Given this list of marker genes GJB6, TRBV7-4, TRBV7-7, GLRA3, ABCC8, CAV2, HTR3C, FCER1G, CDH5, GNG8, PTK2B, KCNF1, CLTC, TRAV36DV7, HFE, ACVR2A, GRM1, GJA1, KCNIP4, DLG3, CHRFAM7A, TRDC, KCNG3, WNT3A, SGCE, SCN2A, NOXA1, CHRNE, ITGA11, TLR2, CATSPERD, CDH22, TRAV27, CD79B, ITGA8, KCNA6, KCNA2, IGF1R, TRBV24-1, GJA9, CHUK, CACNA1C, RAMP3, TRBV6-7 (T cell receptor beta variable 6-7 (non-functional)), TRAV20 (NCBI Gene Id 28663), GNG10, ABCG5, ABCC9 (NCBI Gene Id 102724274, ATP binding cassette subfamily C member 9), GNG5B, TRGV1, SHISA7, GNG3, TRBV14, CHRNA4, OLFM3, SUMO1, CHRNA6, TFRC, CNTFR, GJD3, CD79A, KCNK6, GRIN3B (glutamate ionotropic receptor NMDA type subunit 3B), CATSPERB, CHRNA9, TRBV5-4, ABCD4, NOX3 (NCBI Gene Id 57770), HMGB1, ABHD12, TRBV10-3, HLA-DRA, TRAV34, ATP1A4 (ATPase Na+/K+ transporting subunit alpha 4), TRGV9, KCNS3, PSEN1, IGHM, PSEN2, DPP6 (NCBI Gene Id 653748), KCNJ5, CFLAR, CACNA1E, TRBV12-3, GP1BB (NCBI Gene Id 89199), CTNNA1, TRAV9-1, KCNV1, KCNJ3, CLTB, GNAT3, SNTG2 (NCBI Gene Id 728185), ITGA1, CD74, CACNB3, CAV3, KCNH4, KCNH5, PGM5, TRAV14DV4, CACHD1, COL13A1, GRIK4, KCNN1, CHRNA1, ITGB2, VWC2L, SDCBP, DPP10, TRAV3, GNG2, CHRNA7, KCNA4, GJC2, HLA-F, GNB3, TRAF5, TRBV30, GNG12, TRAV12-1, GJB4, SNAP25, TRBJ2-4 (T cell receptor beta joining 2-4), TRAV8-2, TMEM262 (transmembrane protein 262), LRP1, TBC1D5, HCN1, PDE4B, DLG4, GRIK2, TRBV7-1, HTR3B, C6, IL23R, DRD1, CALM2 (calmodulin 2), GRIA4, ABCA2, HLA-E, TRBV17, IL18R1, CDH10, KCNE1, ITGAD, TRBJ2-3, TRAV8-6 (T cell receptor alpha variable 8-6), LIN7B, ADAM8, TRAV8-4, SLC18A3, SCN4B, TRAJ3, CTNNA2, TRBV6-8, CDH24, FAF1, TRBV10-2, KCNJ4, GP9, GNAQ (G protein subunit alpha q), SCN1B, ITGB1, EFCAB9, KCNG4 (NCBI Gene Id 93107), ATP12A, SGCA, CATSPERE, CDH15, NOX1, KCNE4, SNTA1 (syntrophin alpha 1), CDH7, CHRNA2, CD3G, GJB2 (gap junction protein beta 2), HSPA2, GJB1, GNAI1, HLA-DPA1, TLR1, JAK2, KCNN4, GRIA3, ITGA2B, GJB5, CACNA1D, KCNQ5 (potassium voltage-gated channel subfamily Q member 5), SCN8A, FXYD1, KCNJ8, TRBV6-4, TRBV20-1, CACNG7 (NCBI Gene Id 59284), KCNB1, BMPR1A, ATP1A2, STXBP5, DUOX2, SHC1, TRBV19, CDH17, ITGAE, C8G, ATP1B1, HLA-DQA2, KCNAB3, FADD, CDH18, SCN2B, SCN1A, KCNJ11, NCF4, GJA10, KCNC1, AP2A2 (NCBI Gene Id 25955), TRAV13-1, CD40, SCN5A, GNGT1, CATSPER1, GNB5, HTR3D, CNIH3, CD6 (NCBI Gene Id 923), ITGA7, ATP1B3, VCAM1, CD3D, CDH26, GNG7, ERBB2, ITGAX, HLA-DOA, PRKCA, FXYD4, C2CD6, CDHR3, RAC1, SGCZ, C9, CHRNB3, DAG1, TRGV3, TRAV4, GRID1, KCNQ2, GNB2, GNAI2, HLA-DMB, KCNE3, AP2M1 (adaptor related protein complex 2 subunit mu 1), TRBV29-1, CLTA, ITGB5, KCNC3, INSR, TRBV5-1, TRBV7-2, GRIA2, BIRC2, TRBV18, CALM3, SHISA9, FKBP1A (FKBP prolyl isomerase 1A), KCNA5, SACM1L, GNAS, KCNA7, TRAV8-3, KCNIP3, GRID2, ACVR1, TRAV7, IKBKB, HLA-C, TRAV17, KCNMA1, FCGR3A, TRBJ2-5, GJD2, TMED10, TRBJ1-3, FLNA (NCBI Gene Id 8272), TRAC, TRBC1, TRBJ1-4, IL6ST, LIME1, TRAV41, GP1BA (glycoprotein Ib platelet subunit alpha), CORO1C, FAS, VAMP2, TRAV5, HCN2, LIN7C, KCNQ1, PSENEN, PICALM, LRP6, RET, TRBV4-2, FLOT1, GNB1, AP2B1, TRAV29DV5, ERBB3 (erb-b2 receptor tyrosine kinase 3), GRIA1, KCNV2, ATP6V0D2, GABBR1, TRAF2, TRAV12-3 (T cell receptor alpha variable 12-3), CNTNAP2, CYBB, GJA5 (gap junction protein alpha 5), SCN3B, ATP4A, SHISA6, ITGA3, HLA-DRB3, KCNB2, TF, ACVR1C, GRIN2C (NCBI Gene Id 2905), ABCB6, GNG11, CHRNG, KCNH1, ITGB8 (NCBI Gene Id 3696), TRAV26-2, APC, KCNJ9, APH1B, ACVR1B, NCF1, KCNMB4, TRBJ1-1, TRAV26-1, ITGB6, GJC3, GNAT2, IGHE, CHRNB4, TRAT1, EVC, KCNH2, SNTB2, ITGB7, DLG1, AP2S1, KCNAB2, CACNA1S, IL13RA1, TRBV25-1, AHNAK, ITGA2, KCNS2, GJA4 (gap junction protein alpha 4), GNA14, HTR3E, SYK, TRBJ1-2, CACNG3, LRRC26 (leucine rich repeat containing 26), CDH12, CACNG2, CASP10, GLRB, HLA-A, TRBV11-2 (NCBI Gene Id 28581), SGCB, JUP, TRDD1, KCNG2, TRBV13, C8B, GNA12, TRAV6, GRIN2B, KCNA1, SHISA8, TRAF3, SLC7A5, TRGV4, TRAV30, TGFBR1, SCN11A, HLA-DQB1, CDH8, CASP3, TRBV5-5, AP2A1, LILRA4, CAV1 (NCBI Gene Id 857), TRAV10 (T cell receptor alpha variable 10), NCF1C, ATP1A1, GRIN1, TRBC2, TRBJ2-1, HLA-DOB, CHRNA5, NHERF1, IL6, TRAV12-2, CTNND1, CACNA1H, ITGB4, CHRNB1, HCN3, TRBJ1-6, TMEM249 (NCBI Gene Id 648673), RYR1, BTBD8, NOX4, APH1A, DUOX1, CATSPER3, TRAV35, SNTB1, GNAT1, CHRND, TRGV10, TRAV25, IL6R, TRBV4-1, TRBV16, ABHD6, HTR3A, CACNG5, TRDJ1, KCNJ2, CD8B, CDH11, SGCD, KCNS1, TRBV5-3, KCNQ4, HTRA2, CATSPERG, IL12RB1, TRAV21, PTPN6, HLA-DMA, TRBV27, CACNB2, EMILIN1, CNIH2, GRIK5, CSF2RA, GNGT2, KCNC4, LRRC38, CACNA1G, KCNMB1, CALCR, S100A10, TRBV28, FZD8, LRRC52 (NCBI Gene Id 440699), TRDV1, CHRNA3, LRRC55, CASP8, HCN4, CACNG6, BMPR1B, PDGFRA, EPS15L1, ALCAM, KCNJ14, ABCG8, CHRNB2, KCND3, CDH19, KCND1, CACNB1, STON2, TRADD, LIN7A, CDH20, GABBR2, TRAV22, TRAV1-2, TGFBR3, NOXO1, TRBD1, EVC2, KCNJ6, CD4, GRIN3A, TRBV6-5, MR1, VTN, KCNG1, CACNA2D2, CACNA2D4, TSPAN32, CACNA1B, NEO1, CACNG1, C7, EFCAB7, GJD4, KCNJ16, ATP1B2, TRAV2, LYN, TRBV12-5, KCNE5, TRAV19, FLOT2, TRBV10-1, NOX5, TRBV2, HLA-DPB1, TLR6, DIABLO, SCN10A, ATP1B4, CDH13, RAMP2, CATSPERZ, GPR156, GRIK3, TRGC2, IFNLR1, HLA-DRB5, TRDV2, KCNIP1, GFRA1, TGFBR2, KCNMB2, STAC3, TRDV3, CACNA1I, GJA8 (NCBI Gene Id 2703), TRBV12-4, GNA13, TRBV3-1, TRBV7-9, TRAV38-2DV8, ABCB8, TRBV6-1, GJB3, ACVRL1, NCF1B, ANXA2, CATSPER2, INSRR, ITGA6, CACNG8, GRIK1, RAMP1, ATP6V0D1, SLC3A2, UTRN, CDH6, RAC2, RNF31 (ring finger protein 31), GNA11, ZAP70, KCND2, SCN7A, HJV, GP5, HLA-B, C8A, IGF1, CSF2RB, CRB1, INHA, TRAV40, CALCRL, GNAO1, KCNQ3, GJA3, TRGV5, DRD2, DLG2, CRB2, HLA-DRB4, CEACAM1, SYNJ1, CYBA, CACNA2D3, CALM1 (NCBI Gene Id 801), CDH1, TRAV39, STON1, PDE4D, TRGC1, EGFR, IL2RA, DCHS1, NCF2, ITGA4, OLFM2, TRAV9-2, ITGAL, IL10RB, ITGB3, CRB3, TRBJ2-2, KCNA10, TRBJ1-5, TRBV11-1, CSF2, GNB4, CTNNB1, KCNIP2, ITGA5, GJE1 (NCBI Gene Id 100126572), GJB7, CACNA1F, SORBS1, HLA-H, CTTN, TRGV11, GNG4, IL2RB, TRBV9, TRAV8-1 (NCBI Gene Id 28685), TRAV13-2, SKAP1, KCNAB1, GRIN2A, SCN9A, TRBJ2-7, GNAI3 (G protein subunit alpha i3), TYK2, KCNMB3, AMIGO1, GNAZ (NCBI Gene Id 2781), HLA-DQB2, BMP2, CPT1C, GRB2, SLC6A3, TRBV7-3, ITGA10, EPS15, KRT19, IFNL1, TFR2, CD8A, KCNA3 (NCBI Gene Id 3738), TNK2, TRGV8, ITGA9, CACNA1A, SGCG, GNA15, CATSPER4, TRBV7-6, EPS8, KCNE2, TRAV1-1, SSPN, ACVR2B, TRAV18, SCN4A, GNG13, ATP4B, SGIP1, NCSTN, KHDRBS1, CACNG4, DMD, TRAV38-1, ITGBL1, TRAV16, STX1A, GJC1, C5, MS4A2, CACNA2D1, CDH23, TRAV24, CD247, MPP7, B2M, TRGV2, PSG9, HLA-DRB1, CBL, CDH4, TRAV23DV6, RIPK1, IL18RAP, PORCN, CDH2, TRBV23-1, RAC3, VWC2, TRBV11-3 (NCBI Gene Id 28580), GRIN2D, CDH3, GNG14, ATP1A3, KCNK1, CD3E, HLA-DQA1, APBB1IP, TRBV5-6, APC2, AKAP9, FXYD2, TRBV5-7, GNG5, OSMR, TRAF6 (NCBI Gene Id 7189), ITGAV, SCN3A, TRBJ2-6, IRS1, HLA-G, NRN1, CDH9, KCNK2, ITGAM, HSPG2, LRP5, PDGFA, KCNC2 (NCBI Gene Id 3747), TRBV6-6, GNAL, SNTG1, CACNB4, here is a description of the gene set: Any protein complex that is part of the plasma membrane. Human Gene Set: GOCC_PLASMA_MEMBRANE_PROTEIN_COMPLEX species: Homo sapiens